The following is a description of a gene set: part of: Coagulation pathway Reactome Pathway: Fibrin formation electronically inferred by orthology from the curated human pathway species: Mus musculus This event has been computationally inferred from an event that has been demonstrated in another species.<p>The inference is based on the homology mapping from PANTHER. Briefly, reactions for which all involved PhysicalEntities (in input, output and catalyst) have a mapped orthologue/paralogue (for complexes at least 75% of components must have a mapping) are inferred to the other species., and this is the list of marker genes: F2, Itga2b, Serpina5, F13a1, Serpind1, Proc, Fgg, F13b, Serpine2